The following is a description of a gene set: Human Gene Set: GOBP_MACROPHAGE_CYTOKINE_PRODUCTION species: Homo sapiens The appearance of a macrophage cytokine due to biosynthesis or secretion following a cellular stimulus, resulting in an increase in its intracellular or extracellular levels., and this is the list of marker genes: EPX, NLRX1, RIPK2, TGFB2, LILRB1, TLR4, LITAF, TLR7, UBE2J1, PYCARD, PRG2, ACP5, WNT5A, TICAM1, CARD9, SEMA7A, HLA-G, TGFB1 (transforming growth factor beta 1), TLR3, CUEDC2, TWIST1, P2RX7, SIRT1, CD74 (CD74 molecule), IRAK3, AXL, MYD88, SPON2, LAPTM5, ATG9A, NOD1 (NCBI Gene Id 10392), PLCG2, PANX1, MAPKAPK2, TGFB3, GPRC5B, RTN4, CD36